Given this list of marker genes Vps50, Eipr1, Vps52, Vps53, Vps51, here is a description of the gene set: Mouse Gene Set: GOCC_EARP_COMPLEX A quatrefoil tethering complex required for endocytic recycling. studied in species Mus musculus